The following is a description of a gene set: species: Mus musculus Mouse Gene Set: GOCC_MICROBODY Cytoplasmic organelles, spherical or oval in shape, that are bounded by a single membrane and contain oxidative enzymes, especially those utilizing hydrogen peroxide (H2O2)., and this is the list of marker genes: Pex16, Cat, Pex14 (peroxisomal biogenesis factor 14), Plaat1, Tkt, Vim, Pxmp2, Tmem35a, Dhrs4, Mul1, Pjvk, Mtarc2, Pex19, Pecr, Agxt, Ptgr3, Pex5, Amacr, Serhl, Fabp1, Tmem135, Aldh3a2, Gstk1, Acot6, Sod1, Idh1, Cav1, Mavs, Paox, Hao2, Nudt7, Hmgcl, Acsl3, Pipox, Pex3, Plaat3, Ephx2, Pex12, Idh2, Pex13, Acsl1, Lacc1, Mlycd, Hmgcr, Akap11, Ide, Acnat2, Hspd1, Slc25a17, Ech1, Acsl4, Fdps, Fis1, Pnpla8, Slc27a2, Pex11a, Mgst1, Acad11, Far1, Nudt17, Tirap, Acot4, Pex11g, Rab8b, Gbf1, Ehhadh, Acox1, Far2, Phyh, Mvk, Pex2, Arf1, Myo5a, Acox3, Syt7, Sting1, Eci2, Idi1-ps1, Pex10, Scp2, Fndc5, Prdx5, Pmvk, Abcd4, Pxt1, Pex6, Eci3, Trim37, Abcd1, Crat, Marf1, Pex26, Mvd, Dnm1l, Pex11b, Slc22a21, Idi1, Hacl1, Acot5, Agps, Idi2l, Kcnip4, Mgat4a, Szt2, Isoc1, Abcd3, Hsd17b4, Acox2, Decr2, Pex5l, Dao, Nudt19, Acoxl, Tysnd1, Ddo, Atad1, Pik3c3, Baat, Mff, Acot3, Acsbg1, Urah, 2310039H08Rik, Pex7, Hao1, Acsl6, Gnpat, Rida, Acot8, Mpv17 (NCBI Gene Id 17527), Hsdl2, Cd33, Lonp2, Pex1, Depp1, Uox, Crot, Acnat1, Nos2, Abcd2, Ccdc33, Pxmp4, Prdx1, Acaa1a, Atm, Nudt12, Mpv17l, Dhrs7b, Nbr1, Vwa8, Acaa1b, Acbd5, Idi2, Xdh, Urad, Pomc